Given this list of marker genes SYNE4, TMEM259, HAND1, FOXA3 (forkhead box A3), ITGB4, JAM3, MBD4, IKBKG, BHMT2, CDC25C, IQGAP3, BCAT1, FAM53A, GNAT1, BATF3, SUGP2, ENPP2, FBXO6, POLD3, CPA3, SPOP, TBRG4, MECR, PCK2, CIPC, PENK, CTDP1, RAD23B, TARS2, PLP1, RPAP3, FAM220A, DDX10, ACOT2, RCN3, HSD3B1, MYLK, ALX4, BIK, AADAT, SMYD5, MMP16, UPP1, ARHGEF25, SMYD2, MAT1A, SNHG11, POLR1C, RSPO2, ACADS, BAIAP2, TMEM70, CACNA1B, HS3ST3A1, ITCH, EGFL8, PRG2, MEG3, ZNF326, CCKBR, ADH7, KRT20, S100A3, LYPLA2, TEAD1, GATA1, ATP9A, HTR1A, DNPEP, DHODH, NR5A1, CYB561, TM2D3, FTL, PDZK1, GTPBP2, TRDMT1, BEX4, ERF, SST, FEZF2, IL7, FIGNL1 (fidgetin like 1), FAM241A, CHERP, MUC13, DAO, CTSW, TAF1B, CYP1A1, FRAT2, LEPROT, PRADC1, PIGR, TMEM141, ZFTRAF1, PSMB10, FABP5, ASGR2, KCNJ11, AKR1C4, YIPF3 (NCBI Gene Id 25844), COL9A3, CALB2, LIPC, EIF4ENIF1, NF2, ZFAND5, LTBP2, OPN1LW, GGA2, QDPR, RACK1, FAM216A, KRT31, ARL10, CINP, HLX, IL18RAP, NEUROG1, LHX8, EXOSC5, RNF26, AGR2, FEZ1, CENPC, SYNJ2BP, HP, RMC1 (regulator of MON1-CCZ1), ZNF35, F7, SLCO5A1, IBSP, PDX1, SLC6A12, CHGB, CHRNA7, GSTM1, EPHA4, SERAC1, COPZ2, FAHD1, TCF7, KERA, EFNA1, ALDH1A1, CCNB1IP1, TANGO2, NDUFS4 (NCBI Gene Id 4724), INO80C, WNT3, HOXD13, FGD1, MRPL48, CLN8, PTGER1, DNM2, TM7SF2 (NCBI Gene Id 7108), SLC38A5, CANX, FHL2, CYBC1, SLC2A1, HYOU1, B4GALT1, IFNA1, GABRG1, POU2AF1, PFKFB3, PRKACA, SFN, DHX30, FLVCR2, WT1, LHX9, HOXD8, TNFAIP8L1, CNGA1, CDC20, NRSN1, CEP89, KLK4, FZD7, ZBTB37, SLC35C2, TRAIP, QRSL1, B3GALT4, FGR, IFI27, CST7, CSF3, PTTG1, MAGEB4, TIMM10 (NCBI Gene Id 26519), HOXB6, TIAM2, LCK, CDH6, OXNAD1, here is a description of the gene set: Human Gene Set: GSE43956_WT_VS_SGK1_KO_TH17_DIFFERENTIATED_CD4_TCELL_UP studied in species Homo sapiens Th17 cells are highly proinflammatory cells that are critical for clearing extracellular pathogens like fungal infections and for induction of multiple autoimmune diseases1. IL-23 plays a critical role in stabilizing and endowing Th17 cells with pathogenic effector functions2. Previous studies have shown that IL-23 signaling reinforces the Th17 phenotype by increasing expression of IL-23 receptor (IL-23R)3. However, the precise molecular mechanism by which IL-23 sustains the Th17 response and induces pathogenic effector functions has not been elucidated. Here, we used unbiased transcriptional profiling of developing Th17 cells to construct a model of their signaling network and identify major nodes that regulate Th17 development. We identified serum glucocorticoid kinase-1 (SGK1), as an essential node downstream of IL-23 signaling, critical for regulating IL-23R expression and for stabilizing the Th17 cell phenotype by deactivation of Foxo1, a direct repressor of IL-23R expression. A serine-threonine kinase homologous to AKT4, SGK1 has been associated with cell cycle and apoptosis, and has been shown to govern Na+ transport and homeostasis5, 6 7, 8. We here show that a modest increase in salt (NaCl) concentration induces SGK1 expression, promotes IL-23R expression and enhances Th17 cell differentiation in vitro and in vivo, ultimately accelerating the development of autoimmunity. The loss of SGK1 resulted in abrogation of Na+-mediated Th17 differentiation in an IL-23-dependent manner. These data indicate that SGK1 is a critical regulator for the induction of pathogenic Th17 cells and provides a molecular insight by which an environmental factor such as a high salt diet could trigger Th17 development and promote tissue inflammation. Genes up-regulated in CD4 T helper Th17 cells: wildtype versus SGK1 knockout. from publication Wu C, Yosef N, Thalhamer T, Zhu C, Xiao S, Kishi Y, Regev A, Kuchroo VK (PMID 23467085)